Given this list of marker genes SLX1B (NCBI Gene Id 79578), XRCC3, SLX1A, EME2, EME1, MUS81, GEN1, RAD51C, TEFM, here is a description of the gene set: studied in species Homo sapiens Catalysis of the endonucleolytic cleavage at a junction such as a reciprocal single-stranded crossover between two homologous DNA duplexes (Holliday junction). Human Gene Set: GOMF_CROSSOVER_JUNCTION_DNA_ENDONUCLEASE_ACTIVITY